The following is a description of a gene set: studied in species Homo sapiens Reactome Pathway: Signaling by LTK part of: Signaling by Receptor Tyrosine Kinases Leukocyte tyrosine kinase (LTK) is a transmembrane receptor tyrosine kinase that is a member of the insulin growth factor receptor superfamily. LTK is most closely related to the ALK receptor, and may have originated as a result of a duplication event of the ALK gene. The extracellular domains of ALK and LTK are characterized by a membrane proximal EGF-like (EGFL) module, a unique 250 amino acid glycine rich (GR) domain that, in Drosophila, is essential for function, as well as a TNF-like (TNFL) module. The ALK ECD additionally contains two MAM domains, an LDLa domain and a heparin-binding domain (HBD) that are not present in the LTK receptor. These differences in ECD may contribute to differences in the ligand binding affinities of the two receptors.<br>LTK is activated by the binding of cytokines ALKAL1 and ALKAL2 to the ECD. Ligand binding induces trans-autophosphorylation in the intracellular domain of the receptor and promotes the interaction and activation of downstream signaling molecules such as SHC, IRS1, CBL and PI3K with the phosphorylated receptor. Note however that much of the early functional studies on LTK were conducted before the identification of ALKAL1 and 2 as physiological ligands. In consequence, many of these studies were carried out using chimeric receptors consisting of the ECD (and stimulating ligands) of well-characterized receptors fused to the intracellular domain of LTK.<br>The exact role of LTK signaling is likewise not fully elucidated. Expression of the chimeric LTK proteins described above promotes neurite outgrowth and cell survival. A role for LTK in the regulation of transport from the ER to the Golgi has also been proposed, and one study suggests that LTK may actually bean ER-resident protein. More recently, fusions of LTK have been identified in non-small cell lung cancer., and this is the list of marker genes: ALKAL2, SHC1, LTK, PIK3CB, PIK3R2, IRS1, PIK3CA, ALKAL1, GRB2, SOS1, PIK3R1, TNK2